The following is a description of a gene set: Any process that stops, prevents, or reduces the frequency, rate or extent of signaling pathways initiated by the cross-linking of an antigen receptor on a B- or T cell. species: Mus musculus Mouse Gene Set: GOBP_NEGATIVE_REGULATION_OF_ANTIGEN_RECEPTOR_MEDIATED_SIGNALING_PATHWAY, and this is the list of marker genes: Ezr (NCBI Gene Id 97496), Lgals3, Elf1, Prnp, Plcl2, Ptpn6, Dusp3, Pawr, Lilrb4b, Ptpn22, Dgkz, Btn2a2, Lilrb4a, Btnl2, Ptpn2, Cd160, Lpxn, Cd22, Laptm5, Gps2, Dusp22, Itpripl1, Cblb, Ptprj, Sh2d1a, Cd300a, Phpt1, Thy1, Sla2, Ubash3a, Fcrl5, Pvrig, Nck1, Ceacam1, Btrc